The following is a description of a gene set: Any process that activates or increases the frequency, rate or extent of T-helper 2 cell differentiation. Mouse Gene Set: GOBP_POSITIVE_REGULATION_OF_T_HELPER_2_CELL_DIFFERENTIATION studied in species Mus musculus, and this is the list of marker genes: Tnfsf4, Nlrp3, Il18, Prkcz (NCBI Gene Id 97193), Il6, Il4ra, Rara